The following is a description of a gene set: Mouse Gene Set: GOBP_NEGATIVE_REGULATION_OF_DNA_METABOLIC_PROCESS studied in species Mus musculus Any process that stops, prevents, or reduces the frequency, rate or extent of the chemical reactions and pathways involving DNA., and this is the list of marker genes: Foxp3, C1qbp, Ankle1, Atr, Parpbp, Pot1a, Adipoq, Src, Exosc10, Klhl15, Gnl3l, Gja1, Mad2l2, Zranb3, Mapk15, Riox1, Rmi2, Slx4, Pinx1, Abl1, Parp1, Blm, H1f10, Rad18, Dffb, Parp3, Atm, Tinf2, Shld3, Chek1, H1f6, Gmnn, Msh2, Mre11a, Pot1b, Shld2, Rif1, Gzma, Rad50, Xrcc4, Cdkn1a, Stn1, Dach1, Tspyl2, Niban2, Nudt16l1, Acd, Inppl1, Dnajc2, H1f9, Ttf1, Ubqln4, Otub1, Dynll1, Smg6, Nat10, H1f5, Enpp7, Rtel1, Dcp2, Pds5a, H1f4, Cgas, H1f1, Tipin, Rps3, Pml, Hnrnpc, Fbh1, Ankrd1 (NCBI Gene Id 12907), Tent4b, Ctc1, Terf1, Lig3, Zscan4c, Smchd1, Ercc4, Radx, Senp3, Wapl, Csnk2a1, Rnf169, Xrcc1, Pif1, Xrcc5, Kcnk2, Msh3, Aunip, H1f3, Ercc1, Hnrnpu, Terf2ip, Trp53bp1, Plk1, Hmga2, Tnks, Polq, Ahr, Setd7, Cyren, Sub1, Trp53, Mlh1, Sgf29, Hsf1, Kmt5a, Cdt1, Nmnat1, Ndfip1, Ercc6, BC037156, Terf2, Ten1 (NCBI Gene Id 69535), Rad17, Ogg1, Nppc, Kat5, H1f8, Atg7, Helb, Rgn, Fancb, Dffa, Twist1, Recql5, Hcrt, Dusp1, Bcl6, Nbn, Mcrs1, Gtpbp4 (NCBI Gene Id 85330), Shld1, Fbxo5, Msh6, H1f2, Timeless, H1f0, Tnks2